The following is a description of a gene set: species: Homo sapiens Human Gene Set: GOBP_GLIOGENESIS The process that results in the generation of glial cells. This includes the production of glial progenitors and their differentiation into mature glia., and this is the list of marker genes: MYB, CTNNB1, LAMC3, EIF2B2, PRKCH, MMP24, SIRT2, MIR221, MIR125B1, SH3TC2, BIN1, MAP2K2, GFAP, AREG, RHOA, MXRA8, GSX2, CNP, C1QA, IL6, TUBA1A, SRSF1 (NCBI Gene Id 650453), DLX1, GLI3, OLIG2, ID4, EIF2B5, KRAS, CDH2, RELA, MBOAT7, PRMT5, CREB1, MYRF, EMX1 (NCBI Gene Id 2016), LYN, VTN, PTPN11, METRN, ARHGEF10 (Rho guanine nucleotide exchange factor 10), PTN, CDK1, GCM1, S100A8, TLR2, COL3A1, CSF1, POU3F1, PPP1CC, S100A9, PALS1, LIF, DAG1, DLG5, NTRK2, SLC25A46, PAFAH1B1, ETV5, SPINT1, NCSTN, NR1D1, GPR37L1, ORC3, GPR17, PARD3, MED12, MAL, TNF, PAX6, NEUROD4, TTC21B, MIR146A, SKI, PENK, FGF5, LEPR, TLR4, SOD1, METTL3, MMP14, TGFB1, MFSD8, ABCC8, HDAC1, NR3C1, GAP43, HES5, CRKL, VPS13A, APP, ZNF365, SRGAP2 (NCBI Gene Id 440748), EZH2, ABCA2, RNF112, EIF2B1, MDK, MAG, TSPAN2, NKX2-2, TPPP, RAF1, SRGAP2C, NKX2-1, PTPRB, IDH2, E2F1, COL6A1, CDK5, CX3CR1 (C-X3-C motif chemokine receptor 1), CCR2, LPAR1, SUN2, GPR183, IL34, SLC45A3, DLX2, MYCN, NAB1, SOX10, ATP1B2, EED, ADGRG6, CERS6, NDN, CDK5R2, NKX6-1, TMEM98 (NCBI Gene Id 26022), CNTF, LARGE1, ASCL1, CXCR4, C5AR1, SOX2, EOMES, ANO1, NTRK3, PAX2, IL1B, ZNF488, WDR47, PHOX2B, CSPG4, HES1, DAB2IP, ERBB2, PTEN, RB1, EGR2, GRB2, ADGRG1, HDAC2, SERPINE2, GPM6B, CDKN2C, P2RY1, CDK5R1, F2, LEF1, CLCN2, MAPT, CLU, P2RX4, NAB2, AGER, PLPP3 (phospholipid phosphatase 3), VAX1, CCDC85C, STAT3, CRB1 (crumbs cell polarity complex component 1), ABL1, MIOS, EPHA4, TREM2, RELN, PLP1, DLL1, CD9, PLEC, SCRIB, B4GALT6, SOX8, TP73, SOX13, CCDC39, DUSP15, PICK1, GSTP1, STAP1, ZEB2, PTPRZ1, SHH, PPP3R1, KLF15, MIR142, LTA, WASF3, FGF2, TNFRSF1B, TTBK1, IL33, TSPO, PFKFB3, CCL2, ITGB4, WDR1, ATXN1, BMP2, NFIA, MYD88, NAGLU, DRD3 (NCBI Gene Id 2111), POU3F2, AKT1 (AKT serine/threonine kinase 1), MAPK1, ERBB3, GPC1, HEXB, IL6ST, TRPC4 (transient receptor potential cation channel subfamily C member 4), APCDD1, GRN, GBA1, IFNGR1, MIR181B1, NTN1, FKRP (NCBI Gene Id 79147), MIR222, EIF2B4, HMGA2, EPM2A, NOTCH1, IGF1, BMERB1, CERS2, SOX4, OPALIN, PTPRJ, SLC8A3, DNER, ZMIZ1, DAAM2, LRP8, PRKCI, S100B, CNTNAP1, MECP2, MTOR, SOX6, NF2, DTX1, TAL1, EEF2, FPR2, SUN1, TGFB2, NDP, UFL1, ROR1, MAPK3, RRAS2, DRD1, LRP1, PRX, SLC7A5, SOS1, NSUN5, SOX11 (NCBI Gene Id 6664), TP53, ASCL2, RNF10, GCM2, PRDM8, EIF2B3, NF1, NRROS, BOK, NFE2L1, SUZ12, SOX1, TENM4, SOCS7, METTL14, AZU1, LAMA2, RTN4, LRP2, DISC1, SMO, PITX3, HRAS, DICER1, NDUFS2, NFIB, ADORA2A, FGF10, AKT2, LDLR, MIR26A1, NR2E1, CHRM1, CUL4B, MIR181C, NDRG1, QKI, MYOC, LAMB1, CX3CL1, RRAS, CSF1R, BNIP3, OLIG1, LIN28A, MATN2, CSK, LGI4, ARSG, GPR157, SOX9, PSEN1, B4GALT5, FOXG1, MAP2K1, LAMB2, RHEB, PHGDH, NCMAP, FA2H, CSPG5, NKX6-2, KCNJ10, ID2, CLCF1, TNFRSF21, CCL3, ILK (NCBI Gene Id 55522), VCAN (versican), P2RY12, CNTN1, CDK6, VPS54, SYNE2, VEGFC, ERCC2 (NCBI Gene Id 7269), CERS5, IFNG (NCBI Gene Id 3458), DUSP10, ATOH1, PLAG1, DAB1, NOG, CNTN2, VIM